The following is a description of a gene set: studied in species Mus musculus Mouse Gene Set: GOBP_MACROMOLECULE_DEPALMITOYLATION The removal of palymitoyl groups from a macromolecule., and this is the list of marker genes: Abhd13, Desi2, Abhd17c, Lypla2, Lypla1, Ppt2, Abhd10, Ppt1, Desi1, Abhd17a, Cpt1c, Lyplal1, Abhd12, Abhd17b